The following is a description of a gene set: species: Homo sapiens NF-kappa B regulates normal and pathological processes, including neoplasia, in a tissue-context-dependent manner. In skin, NF-kappa B is implicated in epidermal homeostasis as well as in the pathogenesis of squamous cell carcinoma; however, its function in the underlying mesenchymal dermis has been unclear. To gain insight into NF-kappa B roles in these two adjacent cutaneous tissue compartments, NF-kappa B effects on expression of genes were determined in epidermal keratinocytes and dermal fibroblasts. Although NF-kappa B induced proinflammatory and antiapoptotic genes in both settings, it exhibited divergent effects on growth regulatory genes. In keratinocytes, but not in fibroblasts, NF-kappa B induced p21(CIP1), which was sufficient to inhibit growth of both cell types. Levels of growth inhibitory factor (GIF), in contrast, were increased by NF-kappa B in both settings but inhibited growth only in keratinocytes. These findings indicate that transcription factors such as NF-kappa B can program tissue-selective effects via both differential target gene induction as well as by inducing common targets that exert differing effects depending on cellular lineage. from publication Hinata K, Gervin AM, Jennifer Zhang Y, Khavari PA (PMID 12673201) Human Gene Set: HINATA_NFKB_TARGETS_KERATINOCYTE_DN Genes down-regulated in primary keratinocytes by expression of p50 (NFKB1) and p65 (RELA) components of NFKB., and this is the list of marker genes: HYAL1, THBS1, GPRC5A, SCEL, HOPX, RUNX1, DSG3, KLK7, PPL, RGS2, DAPK1, PTHLH (parathyroid hormone like hormone), CLEC16A, KLK6, SULT2B1, ZNF185, PALM, CEACAM6, UPK1B, ESYT1, CALB1, RIMS2, DUSP4